The following is a description of a gene set: species: Mus musculus Cytokines mediate cell-cell communication in the immune system and represent important therapeutic targets. A myriad of studies have highlighted their central role in immune function, yet we lack a global view of the cellular responses of each immune cell type to each cytokine. To address this gap, the authors created the Immune Dictionary, a compendium of single-cell transcriptomic profiles of more than 17 immune cell types in response to each of 86 cytokines (>1,400 cytokine-cell type combinations) in mouse lymph nodes in vivo. A cytokine-centric view of the dictionary revealed that most cytokines induce highly cell-type-specific responses. For example, the inflammatory cytokine interleukin-1β induces distinct gene programmes in almost every cell type. A cell-type-centric view of the dictionary identified more than 66 cytokine-driven cellular polarization states across immune cell types, including previously uncharacterized states such as an interleukin-18-induced polyfunctional natural killer cell state. Genes negatively differentially expressed in cell type: γδ T cell upon treatment with cytokine: IL-36Ra in mouse lymph nodes in vivo. from publication Cui A, Huang T, Li S, Ma A, Pérez JL, Sander C, Keskin DB, Wu CJ, Fraenkel E, Hacohen N (PMID 38057668) Mouse Gene Set: CUI_T_CELL_GD_IL36RA_RESPONSE_DN, and this is the list of marker genes: Jund, Junb, Pnrc1, Klf2, Cxcr4, Zfp36l2